The following is a description of a gene set: Mouse Gene Set: GOBP_REGULATION_OF_VERY_LOW_DENSITY_LIPOPROTEIN_PARTICLE_CLEARANCE species: Mus musculus Any process that modulates the rate, frequency or extent of very-low-density lipoprotein particle clearance. Very-low-density lipoprotein particle clearance is the process in which a very-low-density lipoprotein particle is removed from the blood via receptor-mediated endocytosis and its constituent parts degraded., and this is the list of marker genes: Apoc1, Apoc3, Lrpap1, Apoc2l (apolipoprotein C2 like), Apoc2